Given this list of marker genes Psmb8, Serpina3g, Nampt, Oasl1, Bst2, Manf, Daxx, Phf11b, Psme2, Tpst1, Zeb2, Mcl1, Gimap9, Irgm1, Sertad2, Ms4a4c, Cxcr5, Trim30d, Stat2, Rigi, B2m, Tap1, Agfg1, Casp8, Eif2ak2, Irf9, Mndal, Trafd1, Isg20, Shisa5, Gramd2b, Gbp9, Rnf213 (NCBI Gene Id 672511), Gimap4, Cybb, Nrip1, Cd47, Tap2, Clec2d (C-type lectin domain family 2, member d), Ifi209, Calhm6, Tor3a, Icam1, Usp18, Irf1, Slfn2, Herc6, Oasl2, Zbp1, Pml, Smchd1, Nlrc5, Ppwd1, Dbnl, Ero1b, Igtp, Cd69, Ifi208, Gbp4, Ifi47, Ifi214, Ifit2, Wars1, Irf7, Ifit3, Trim30a, Sp110, Ppa1, 9930111J21Rik2, Irf8, Apobec1, Pkib, Psmb10, Xaf1 (NCBI Gene Id 327959), Gbp5, Serpinb1a, Ly6a, Gbp3, Samhd1, Isg15, Tlr7 (NCBI Gene Id 170743), Ifi206, Ifi203, Psmb9, Psme1, Helz2, Ifi35, Gbp7, H2-T23, Parp14, Ifi213, Ifi27l2a, Plac8, Zup1, Ly86, Trim12a, Nt5c3, Mitd1, Mrpl30, Socs1, Bcl3, Stat1, Ifitm3, Rtp4, Parp9, Sp100, Slfn5, Slfn8, Tapbpl, Stat3, Nmi, Ctss, Gbp2, Usp25, Psma7, Trim12c, here is a description of the gene set: from publication Cui A, Huang T, Li S, Ma A, Pérez JL, Sander C, Keskin DB, Wu CJ, Fraenkel E, Hacohen N (PMID 38057668) Cytokines mediate cell-cell communication in the immune system and represent important therapeutic targets. A myriad of studies have highlighted their central role in immune function, yet we lack a global view of the cellular responses of each immune cell type to each cytokine. To address this gap, the authors created the Immune Dictionary, a compendium of single-cell transcriptomic profiles of more than 17 immune cell types in response to each of 86 cytokines (>1,400 cytokine-cell type combinations) in mouse lymph nodes in vivo. A cytokine-centric view of the dictionary revealed that most cytokines induce highly cell-type-specific responses. For example, the inflammatory cytokine interleukin-1β induces distinct gene programmes in almost every cell type. A cell-type-centric view of the dictionary identified more than 66 cytokine-driven cellular polarization states across immune cell types, including previously uncharacterized states such as an interleukin-18-induced polyfunctional natural killer cell state. Mouse Gene Set: CUI_B_CELL_IL15_RESPONSE_UP studied in species Mus musculus Genes positively differentially expressed in cell type: B cell upon treatment with cytokine: IL-15 in mouse lymph nodes in vivo.